The following is a description of a gene set: studied in species Mus musculus from publication Yevshin I, Sharipov R, Kolmykov S, Kondrakhin Y, Kolpakov F (PMID 30445619) Mouse Gene Set: RTF1_TARGET_GENES, and this is the list of marker genes: Ddx18, Dhx8, Tanc1, Mtf2, Gm26885, Zfp219, Hsp90aa1, Phf7, Itgb1, Lrrtm2, H2ac5-ps, Snord1b, Eif4a2, H2ac4, Ikzf2, H2bc11, Snord45b, Igf2bp3, Ang, Tpm1, Pum1, Arid2, Gm16251, Peds1, Lbhd1, Aopep, Gin1, Klhl28, Gm9958, Efcab2, Snx5, Ramacl, Rdh10, Ddx5, Rsrc2, Gm36401, Ppp4r2, Pcif1, Stx16, 0610009L18Rik, Dmtf1, Azin1, Ywhaz, Bmpr1a, AI480526, Rnase4, Triobp, Gm10837, Mir3074-2, Hspa1b, 9430015G10Rik, Eps8, 9130213A22Rik, Gm4189, Dusp6, Epn1, Snord73a, Snord2, Snord73b, Tra2b, Mir5136, Macf1, H2ac13, Gpc1, Bap1, Gm16170, Gm24494, Rpl7, Ankrd17 (NCBI Gene Id 81702), Dst, Mir1894, Sf3b1, Gm26387, Sdhaf3, Hnrnpdl, Rpl7a, Btf3l4, Snora64, Mrps18b, H2bc13, Cnn3, Cflar, Nop58, Gm11398, Gm6420, Snora78, Septin9 (NCBI Gene Id 53860), Nt5m, Spaca6, H2ac11, Akap13, Trim41, Mrpl44, H2ac15, Gm24044, Brd2, Hmgb1, Tlx2, Cdca2, Gm17501, Gm23941, Mir1931, Fn1, Wnk1, Rcc1, Senp6, Lmna, Gm10501, Snora9, Gm22489, Eif4g2, Tardbp, Kank3, Actg1, Ivns1abp, Ugdh, Znfx1, Ankrd46, Trbv9, U2af2, Rps8, H4c9, Hspa5, Jdp2, A530013C23Rik, Wee1, Polg2, Des, Gm4890, Gm20033, Snhg9, Gm24029, H4c1 (H4 clustered histone 1), Tgif1, Rbm3, Ints10, Gm26224, Mir100hg (NCBI Gene Id 99733), Atxn2, Polg, Klf16, Eif4a1, B230369F24Rik, E330011M16Rik, Gm26205, Gm23969, Edrf1, Arid1a, Rab10os, Snora57, H2bc22, 5430416N02Rik, Mir378a, Ppp1r10, Snord55, D330041H03Rik, Zfp326, Lrrc75aos2, 1810009A15Rik, B4gat1, Mef2c, Med22, Mir6236, Snord11, Vmp1, Gas5, Thrap3, H2bc6 (H2B clustered histone 6), Sec63, H2bc12, Lhx8, Gm2453 (predicted gene 2453), Atp5f1b, Mir6935, Myh9, Ttn, Slc35e2 (solute carrier family 35, member E2), Fos (NCBI Gene Id 14281), Mdm2, Hnrnpk, Ints5, Klf7, Tcf3, Nudt16, Ecd, Mir24-1, Etf1, Midn, Cep57, Hspa8 (heat shock protein 8), Sfpq, Phtf1, Mgme1, Kmt2c, Mir27a, Sqstm1, Asrgl1, Ubc, Polq, Vma21, Flna, Tagln2, Abhd16a, Lsm6, Gm22748 (predicted gene, 22748), Cyp27a1, Arhgef2, Gm10382, Gm23262, Amotl2, Rpl22l1, H3c15, Gm12279, H2ac8, Rpl5, Nme1, Cox20, Hnrnpf, Txndc12, Snord82, Mir24-2, Tns1, Mir3064, Poldip3, Pdlim5, Pgm3, H4c4, Sgpl1, Rps19, Gm20652, Ftl1, Mtcl2, Mcph1, Gm11175, Zwilch, Snora31, Snord35b, Calm1, Slc20a1, Nptn, Eps15, Ube2g1, Fam149b, Tbce, Gadd45a, Runx1, Cyth3, Maff, Gm22357, Zbtb37, Gm24718, Ipo7, E030042O20Rik, Lsm2, Nufip2, Iscu, Psmg3, Uck2, Tma16, H2bc18, Gm23212, Parp6, Vim, Taf4, Nabp1, Ofd1, Mir23a, Gm26330, Ywhae, Tnnt3, Hnrnpd, Tfdp1, Fhl1, Zbtb7a, BC005537, Gm12439, Ufsp1, Coq10b, Rps2, Agbl3, G430095P16Rik, Wdr36, Snord1a, Gm32950, Fbxw8 (F-box and WD-40 domain protein 8), Pabpc1, Ccnl1, Snhg15, Rpl6, Aco2, Ank1, Ndufa7, H3c10, Gm26287, Tob2 (NCBI Gene Id 73089), AI606473, Sptan1, Zpr1, Phb2, Msh4, Tmsb4x, Phykpl, Snhg5, Eef1g, Wdfy1, Mir17hg (NCBI Gene Id 75957), Atp7a, Baz2b, Cdkn1a, Pum2, Ppp1r1c, Pdlim7, Gm10138, Atp2a2, Rfx3, Ptbp1, Evx1, Actb, Ctnnb1, Rap2a, Mylpf, Zc3h10, Atf3, Fus (fused in sarcoma), Mllt6, Apba3, Dhcr7, Kmt5b, Igfbp5, Gm16833, Gm24067, Rbbp6, C230035I16Rik